Given this list of marker genes EGFR, SPP1, KDR, PTEN, IL6, CD63, SOD1, BIRC5, CD81, EGF, MIR19A, SORBS2, GATA4, MIR455, PDLIM5, MMP9 (matrix metallopeptidase 9), HSPB1, IGF1, TLR4, STAT3, ETS2, here is a description of the gene set: Human Gene Set: WP_EXTRACELLULAR_VESICLES_IN_THE_CROSSTALK_OF_CARDIAC_CELLS Extracellular vesicles in the crosstalk of cardiac cells studied in species Homo sapiens